Given this list of marker genes Abhd17b, Prpf40a, Arrdc3, Dazap2, Gpm6b, Hao2, Zfx, Bmyc, Spdl1, Gabrb2, Rps6ka6, Fam174a, Gmnc, Palld, Slc16a4, Cacna2d1, Fut9, Syn3, Atrx, Oaf, Pgrmc1, Egln1, Nolc1, Jag1, Rhobtb3, Paxip1, Fn1, Tubb2b, Rtca, Luc7l2, Dcaf12l1, C8a (complement component 8, alpha polypeptide), Xpo7, Pbsn (NCBI Gene Id 54192), Adamts18, Zc4h2, Ptpn9, Gm715, Gria2, Zfp874b, Btaf1, Kcna2, Itpr2, Cenpx, Tmem128, Srsf10, Mael, Naip6, Col2a1, Hacd2, Slc39a2, Fam216b, Fam135a, Epha4, Hnrnpm, Vwc2, Stag2, Itga4, Tnfsf10, Abca6, Dipk2a, Klhl1, Kdm5b, Zfp748, Car8, Hspa1l, Il36g, Ccnc, Cetn3 (centrin 3), Esp3, Rab10, here is a description of the gene set: from publication Chen Y, Wang X (PMID 31504780) Genes predicted to be targets of miRBase v22 microRNA mmu_miR_5132_3p in miRDB v6.0 with MirTarget v4 prediction scores > 80 (high confidence targets). studied in species Mus musculus Mouse Gene Set: MIR_5132_3P